Given this list of marker genes RHO, CNGA1, FNTB, CAMKMT, CALM1 (calmodulin 1), GUCA1B, GNB5, GUCA1C, RGS9BP, GUCA1A, METAP2, GUCY2D (NCBI Gene Id 8145), GNAT1, GRK1, METAP1 (NCBI Gene Id 23173), PPEF1, GUCY2F, SAG, GNB1, GRK7, PDE6G, PRKCA, GRK4, PDE6B, SLC24A1, GNGT1, RGS9, FNTA (NCBI Gene Id 2339), CNGB1, NMT1, RCVRN, NMT2, PDE6A, PRKCQ, here is a description of the gene set: Human Gene Set: REACTOME_THE_PHOTOTRANSDUCTION_CASCADE The phototransduction cascade species: Homo sapiens